Given this list of marker genes Set, Nfatc3, Numa1, Gm56637, Ctsc, Hsph1, Gbp7, Mef2c, Rps2, Pck2, Smc4, Nasp, Id3, Tuba1b, Ly6c2, Rhd, Slc20a1, Sgo1 (NCBI Gene Id 98076), Ddx1, Vkorc1, Slc25a20, Lcp1, Crip2, Rbbp7, Abr, Fxyd5, Car2, Josd1, Gm13394, Sec61a1, Ier2, Zyx, Eif4e, Wdhd1, Anp32b, Acp1, Pdk1, Isyna1, Rpn2, Ssbp2, Derl2, Cdkn1a, Plet1, Actn4, Ehd1, C1qbp, Hmbs, Rpa1, Bcl2, Dtd1, S100a9, Lum, Pip4k2a, Ptpn22, Cdca4, Rbl1, Stat4, Gphn, Rom1, Ly6c1, Tuba4a, Brpf1, Tubb4b, Cd36, Lyz2, Ly6a, Dnajb1, Asxl1, Psmb8, Stil, Isoc1 (isochorismatase domain containing 1), Ifrd2, Atp1a1, Cox18, Pacs1 (NCBI Gene Id 245856), Xpo1, Mogs, St3gal6, Gimap4, Ccnd2, here is a description of the gene set: Mouse Gene Set: MORI_SMALL_PRE_BII_LYMPHOCYTE_DN Down-regulated genes in the B lymphocyte developmental signature, based on expression profiling of lymphomas from the Emu-myc transgenic mice: the Small Pre-BII stage. The Emu-myc transgenic mouse has provided a valuable model for the study of B-cell lymphoma. Making use of gene expression analysis and, in particular, expression signatures of cell signaling pathway activation, we now show that several forms of B lymphoma can be identified in the Emu-myc mice associated with time of tumor onset. Furthermore, one form of Emu-myc tumor with pre-B character is shown to resemble human Burkitt lymphoma, whereas others exhibit more differentiated B-cell characteristics and show similarity with human diffuse large B-cell lymphoma in the pattern of gene expression, as well as oncogenic pathway activation. Importantly, we show that signatures of oncogenic pathway activity provide further dissection of the spectrum of diffuse large B-cell lymphoma, identifying a subset of patients who have very poor prognosis and could benefit from more aggressive or novel therapeutic strategies. Taken together, these studies provide insight into the complexity of the oncogenic process and a novel strategy for dissecting the heterogeneity of B lymphoma. species: Mus musculus from publication Mori S, Rempel RE, Chang JT, Yao G, Lagoo AS, Potti A, Bild A, Nevins JR (PMID 18922927)